The following is a description of a gene set: Any process that activates or increases the frequency, rate or extent of type B pancreatic cell proliferation. species: Mus musculus Mouse Gene Set: GOBP_POSITIVE_REGULATION_OF_TYPE_B_PANCREATIC_CELL_PROLIFERATION, and this is the list of marker genes: Reg1, Wnt3a, Sfrp1, Irs2, Ptprn, Pdx1, Igf1, Phip